Given this list of marker genes Ep300, Snw1, here is a description of the gene set: Reactome Pathway: RUNX3 regulates NOTCH signaling electronically inferred by orthology from the curated human pathway This event has been computationally inferred from an event that has been demonstrated in another species.<p>The inference is based on the homology mapping from PANTHER. Briefly, reactions for which all involved PhysicalEntities (in input, output and catalyst) have a mapped orthologue/paralogue (for complexes at least 75% of components must have a mapping) are inferred to the other species. species: Mus musculus part of: Transcriptional regulation by RUNX3